Given this list of marker genes MMP8, PRSS2, FURIN, ELANE, MMP2, KLK2, CTRB1, MMP9, MMP15, PRSS1, MMP1, PLG, CTRB2, CTSV, MMP24, CTSG, MMP11, MMP16, TPSAB1, MMP3, MMP10, MMP7, CTSK, MMP14, MMP25, MMP13, CMA1, KLKB1, TIMP1, SPOCK3, MMP17, TIMP2, COL18A1, here is a description of the gene set: species: Homo sapiens Human Gene Set: REACTOME_ACTIVATION_OF_MATRIX_METALLOPROTEINASES Activation of Matrix Metalloproteinases